Given this list of marker genes CTNND2, EED, GSPT1, ARHGAP11A, ZNF687, UNG, MSH2, CLSPN, NUFIP2, TOPBP1, RASAL2, TAOK2, PRKDC, MYH10, NABP2, NRP2, ASXL2, ARID4A, CDC25A, PCNA, ZMYM2, CCNT1, POLA2, POLE4, PAX6 (paired box 6), SUMO1, STK35, WEE1, DNMT1, EMC3, JADE1, PRRC2C, UBR7, CBX5, USP37, AK2, NOLC1, NIPBL (NCBI Gene Id 25836), PAQR4, E2F8, CASP8AP2, TMEM108, RMI2, DCTPP1, H2AZ1, JADE2, ZBTB4, SLC38A1, RHCE, RRM2, STT3B, CDT1, HOXC10, JPH1, NUP153, POLR1G, SNRPD1, AP4M1, FIZ1, ATAD2, E2F7, DNAJC5G, UFD1, INSM1, VCAN, SIK2, IPO7, RAD51, KPNB1, POLE2, DDX17, DDB2, NUP62, DNAJC9, EMSY, CDC45, ING3, MCM7, ADAMTS2, PHF13, RAVER1, EPHB1, GABRB3, PHF5A, HNRNPUL1, TBX6, UGGT1, KCND2 (potassium voltage-gated channel subfamily D member 2), RHD, NASP, YTHDC1, APPL1, OTUD7B, PRP4K, SASS6, APH1A, SMC6, YBX2, MRPL40, SPINK5, FANCD2, GMNN, SRSF7, PAN2, HS6ST3, EZH2, LUC7L3, MCM8, INTS7, RPS6KA5, PHC1, MCM2, BRME1, CNOT9, STAG2, USP49, SPTB, ACBD6, TRMT2A, NELL2, STMN1, TMEM187, KBTBD7, CDK1, CAND1 (NCBI Gene Id 55832), ZCCHC8, PIM1, H2AC12, MCM6, NCL, TRMT6 (tRNA methyltransferase 6 non-catalytic subunit), SEMA5A, TMEM143, PBRM1, GRIA4, H4C1, CTCF, ILF3, HIRA, MCM3, GEN1, DCK, RIBC1, MAZ, ID3, NSD3, HCN3, H3C1, SP3, GON7, HMGXB4, MCM4, SMC1A, GPRC5B, SOAT1, SLCO3A1, FMO4, SLC6A4, TFAP4, TRMT13, ALDH6A1, SRSF2, THAP8, SREK1, PCSK1, ZNF565, IER5L, E2F1, HNRNPR, SEMA6A, PRPS1, STAG1, RANBP1, CTDSPL2, POLD3, IL4I1, GAPDH, KCNA6, TMPO, MXD3, ZNF362, TREX2, SLC9A5, KBTBD6, SYNGR4, RAB11B, POLD1, PPM1D, WDR62, GINS3, UXT, NFATC2IP, MCMBP, PKMYT1, ACO2, POLR2A, E2F3, ATF5, H2BC12, ZNF644, CDC6, PCYT2, CDCA7, GPAT2, BRMS1L, PPP1CC, ILF3-DT, PODN, RBL1, TYRO3, MEIS2, FBXO5, HMGN2, HNRNPD, EFNA5, KIAA0825, TRA2B, CORT, DNAJC11, HNRNPA1, POLA1, ZNF367, PPP1R8, NECTIN1, MTF2, ATAD5, EHBP1, SMAD6, DMD, FHOD1, ERBIN, ARHGAP6, ZNF524, SMC3, PCLAF, SRSF1, here is a description of the gene set: Human Gene Set: E2F_Q6 species: Homo sapiens Genes having at least one occurrence of the motif TTTSGCGS in the regions spanning 4 kb centered on their transcription starting sites. This matches the transcription factor binding site V$E2F_Q6 (v7.4 TRANSFAC).